Given this list of marker genes RHD, XPO7, NUDT4, RPIA, SLC12A3, TOP1, ISCA1, BLVRB (biliverdin reductase B), CDC27, SELENBP1, CROCCP2, EPB42 (erythrocyte membrane protein band 4.2), RHCE, UROD, GYPE, EIF2AK1, SPTA1, SMOX, TAL1, CA2, XK, OSBP2, ALAS2, EIF1AY, BSG, TFDP2, RNF123, RANBP10, FOXO3, TMCC2, TRIM10, UBE2O, TFDP1, SPTB, NFE2, AHSP, GYPB, PPOX, ACSL6, RAD23A, HMBS, MPP1, RBM38, SNCA, CLIC2, MARK3, RHAG, SLC22A4, GYPC, FBXO7, ERMAP, SLC4A1, TSPO2, GLRX5, GYPA, HBQ1, H1-0, MARCHF8, FBXO9, DCAF11, TRAK2, UBAC1, MAP2K3, FECH, PNP, ANK1, H4C3, TSPAN5, BNIP3L, here is a description of the gene set: Neighborhood of RAD23A RAD23 homolog A (S. cerevisiae) in the GNF2 expression compendium species: Homo sapiens Neighborhood of RAD23A Human Gene Set: GNF2_RAD23A